The following is a description of a gene set: species: Homo sapiens Neighborhood of CDH11 Neighborhood of CDH11 cadherin 11, type 2, OB-cadherin (osteoblast) in the GNF2 expression compendium Human Gene Set: GNF2_CDH11, and this is the list of marker genes: COL5A1, RAI14, LAMC1, PXDN, FKBP9, SRPX, COL1A1, FBN1, PTX3, COL6A2, LOXL1, SERPINE1, COL1A2, THBS2, CDH11, FSTL1, GFPT2, LAMB1, COL3A1, SERPINH1 (serpin family H member 1), FN1, CALU, COL5A2, COL6A1, LOXL2